Given this list of marker genes SLC29A3, RAD21, SDHC, COG1, SMC1A, MRAS, GNB2, NSMF, ARHGEF2, CARS1, MLH1, CDKN2A, WDR19, PPP2R5D (protein phosphatase 2 regulatory subunit B'delta), PHF6, CDH11, AXIN2, DEF6, TNRC6B, COL14A1, PRKN, CYP21A2, CERT1, NF1, WAC, H3-3A, FSHR, TMCO1, SRY, B4GALT1, CDC6, MAP3K1, DPM1, BICRA, HMMR, MSH4, GLI2, PMM2, TERT, RAB18 (RAB18, member RAS oncogene family), PROK2, CYP11A1, SLC25A46, TAF4 (TATA-box binding protein associated factor 4), ZFPM2, CDK4, DDX6, STT3A, VAMP7, TBX3, ERMARD, LMNA, GTF2E2, NTHL1, TMEM94 (NCBI Gene Id 9772), RAF1, CCDC47, GRIP1, SMC3, FLRT3, DHX37, CHRNG, NHLH2, SOS1, EDARADD, CCDC141, WT1, ZC4H2, POU1F1, PIGO (NCBI Gene Id 84720), TIMM50, SPIN4, PEX2, NR5A1, ZNF148, PIGT, RERE, ZFTA, PACS1, LAS1L, SPRY4 (NCBI Gene Id 81848), POC1A, GNE, MBD4, ANOS1, CTNNB1, XRCC3, MEGF8, PPP1CB, FRAS1, FIG4, HDAC4, COX7B, DHCR7 (NCBI Gene Id 6589), MAF, COLEC10, ACD, ALG14, FGFR2, MEG3, VAC14, MPLKIP, ZEB2, ZSWIM7, WNT7A, BMP15, IDH2, EED, ORC1, COQ8A, POLR3A, TWIST2, MASP1, FEZF1, CACNA1C, IBA57, GNAS (NCBI Gene Id 82944), OTX2, AFF4, WDR11, ADNP, ERCC6, KNSTRN, ITGA3, COG7, PNPLA6, JARID2, LZTR1, EIF4A2, PTEN, WLS, BRCA1, SMCHD1, RAD54L, DLK1, ABCD4, BLM, ZBTB20, PMS1, MRE11, CHAMP1, ALMS1, RTL1, PDE11A, TMEM53, KRT10, RNU4-2, MSH2, NR0B1, POLE, PALB2, CASP8, IDH1 (NCBI Gene Id 3417), RAD50, CTBP1, PSMC3IP, ZMYND11, ALG2, FAS, BRIP1, PORCN, CDT1, SOX9, FASLG (Fas ligand), MAPRE2, MEFV, CDH23, INSR (NCBI Gene Id 3643), SLC4A10, POLR3H, WASF1, DES, TFAP2B, PIGV (phosphatidylinositol glycan anchor biosynthesis class V), ACOX1, POLD1, ATR, OPCML, SPRED2, ASH1L, GNRH1, CKAP2L, MUTYH, KISS1, FGF17, SLCO2A1, TACR3, H4C9, ALG3, PIGW (phosphatidylinositol glycan anchor biosynthesis class W), VPS35L, ARHGAP31, WDR37, WNT3, PIGN, FREM2, RIT1, MAB21L1, SEMA3A, WASHC5, SH3PXD2B, AAGAB, RSPO1 (NCBI Gene Id 284654), PIGY, MAP2K1, STAG1, CDKN1B, AKT1, MGAT2, CDKN2C, TGFBR2, SMPD4, PTPRF, KIFBP, TCF20, RBM28, ORC4, DHODH, AMER1, CILK1 (ciliogenesis associated kinase 1), KMT2B, KATNB1, TARS1, ASXL3, BARD1, EXOC2, PALLD, COLEC11, ATM, PGAP2, TTC5, RNF113A, BAP1, AHDC1, DCC, MADD, DUSP6, CPE, MDH2, RASA2, PSMB8, FSHB, NBN, CYB5A, EDA (NCBI Gene Id 90878), KDM6A, KDM1A, HNRNPK, KIAA0586, SMAD4 (NCBI Gene Id 4089), IL17RD, NONO, PLAAT3, BMPR1A, PGAP3, MSH3 (mutS homolog 3), ESR1, KMT2D, FOXA2, YY1, DPYSL5, CASP10, TAF6, SDHD, KRAS, TUBB, SLC35A2, LHB, USP9X, KIF15, CDKN1A, SEMA3E, DYRK1A, ERCC3, CDKN2B, RNF43, NSUN2, CBL, ALG8, AARS1, MAN1B1, CDH1, IKBKG (NCBI Gene Id 8517), EPCAM, CDC45, PIGL, HPGD, SLC6A17, PTPN6, NQO2, ALG12, SOS2, PSAT1, BRAF, LETM1, HSD17B3, WRN (WRN RecQ like helicase), PMS2, KDM6B, RRAS, NIPBL, RAB3GAP2, TTI1, MEN1, GATA4, HS6ST1, B3GLCT, LEP (leptin), NIN (ninein), CDH2, NRAS, ACTB, NUP107, RNF216, KDM5B, RB1CC1, LAMA5, GTF2H5, FAT4, MDM2, HESX1, AR, NSD2, RRAS2, NFIX, KCTD1, DPAGT1, SMS, LBR, SLC25A24, MGMT, STK11, HSD3B2 (hydroxy-delta-5-steroid dehydrogenase, 3 beta- and steroid delta-isomerase 2), PIK3CA, UBR1, CYP17A1, CHST3, BMP6, SOX3 (SRY-box transcription factor 3), PIK3CD, ATN1, GPR101, SMC5, RABL3, APC, GMNN, SPTBN1, POT1, FMR1, GPC3, TBX4, LEPR, SRD5A3, PTPN11, RAD51, CUL4B, SEMA4A, PHB1, CHEK2, FGF8, PRLR, PROKR2, ASXL1, AIP, ERBB2, BRD4, UBE2A, ANTXR1, ORC6, BNC1, SRA1, RIPK4, PLXND1, SLC22A18, TERF2IP, AKT2, PROP1, GPC4, INTU, HFE, CCDC22, ARCN1, RSPO2, EFNB1, GDF11, AXL, SETBP1, TP53, MECP2, HS2ST1, MRPS22, TBL1XR1, SCN4A, EBF3, CSPP1, PRKAR1A (NCBI Gene Id 5573), SET, TCF4, NDNF (neuron derived neurotrophic factor), KLLN, ALG11, ALG9, TRAF7, GNPTAB, KANSL1, CPLX1, SMARCA2, SPIDR, WWOX, SDHB, NECTIN1, C18orf32, REV3L, NELFA, USF3, CYP11B1, ERCC2, TRRAP, TAC3, HDAC8, MSH6, PIGG, EXTL3, FGFR1, RPS20, RFT1, TWIST1, IRF4, KAT6A, FOXL2, SEC23B, UBA2 (NCBI Gene Id 10054), RAD51D, CPT2, KISS1R, EZH2, GNRHR, CHD7, PEX3, BRCA2, MITF, RAD51C, PPM1D, TFAP2A, MC1R, LHX4, SOX10, AMMECR1, TOGARAM1, CDK13, TP63, IGF1R, NUP188, SOX6, here is a description of the gene set: Abnormality of the breast An abnormality of the breast. species: Homo sapiens Human Gene Set: HP_ABNORMALITY_OF_THE_BREAST